The following is a description of a gene set: Mouse Gene Set: GOMF_3_OVERHANG_SINGLE_STRANDED_DNA_ENDODEOXYRIBONUCLEASE_ACTIVITY studied in species Mus musculus Catalysis of the hydrolysis of ester linkages within 3' overhang single-stranded deoxyribonucleic acid by creating internal breaks., and this is the list of marker genes: Xrcc1, Ercc4, Xrcc4, Aste1, Ercc1